Given this list of marker genes TMEM45A, LLGL2, FAM110C, SLFN12, AMPD3, PDE3B, ABHD6, NOD1, SLC2A3, SLC35B4, CEP126, SLC25A33, GREM2, TMEM266, PREX2, BICD1, RUNDC3B, TCF7, FOXRED2, GCH1, TNFSF13B, ITPR1, ADAMTSL3, NIPSNAP1, GLIPR1, C11orf52, GPRC5A, GPR149, INSL6, RAB27B, ZSWIM6, REXO4, GDF15, TMEM109, FRAT1, RBKS, SLC16A13, UCP2, ZNF593, PRRG4, SH3RF3, TMEM141, ALDH7A1 (NCBI Gene Id 64414), IL1RL2, PIK3R5, SH3BP5 (SH3 domain binding protein 5), PCDH9, GREM1, MAN1A1, SPRY4, FETUB, ZNF518B, ATRNL1, CPA6, ACSBG1, BNC1, LPCAT4, SLC4A8, BRINP3, TLE4, CREB5, S1PR3, PLCB1, MRPL35, GATA6, MLF1, MFSD2A, FZD7, LY9, NREP (neuronal regeneration related protein), MRPS31, ARNT2, KIAA1217, OSR1, PHYH, DMRT2, HHAT, CHN2, GATA4, UNC5B, ELOVL4, CTSC, PARM1, KLF4, DNAJC27, DDX19B, EXOC6 (exocyst complex component 6), ZNF595, SRD5A1, DCN, HAVCR2, KIAA1671, WDR31, SYNGR3, STAG3, GPX7, GJB3, TNFSF9, SASH1, AIG1, RNF128, STXBP2, MT1X, WWC1, PTPRG, RBPMS, PEBP1, DNPH1, NAIP, PTPN13, CTSK, HLA-B, WNK3, EZR, DUSP6, FOXQ1, ICA1, EPOR, FBLIM1, DUSP16, MYL9, CRYAB, PRELID3A, KRT19, H2AJ, NEDD9, FEZ1, SCAMP5 (NCBI Gene Id 192683), LPAR2, HIVEP2, NANOS1, OVGP1, RALGAPA2, HECTD2 (HECT domain E3 ubiquitin protein ligase 2), CA12, HS3ST1 (NCBI Gene Id 9957), GPR176, LPAR6, VSTM5, LMO7, PRKAG2, TMEM170B, ARHGAP26, JAM2, ALKBH7, SLC16A3, CMBL, RBM12B, MAP3K6, RCOR2, RAB6B, GDPD1, OLR1, WBP11, SLC35G1, AIM2, SNAI1, ZNF503, LFNG, F2R, TMEM185B, RBM47, DMPK, NOX4, ATOH8, COA3, MPP7, GPR39 (NCBI Gene Id 2863), here is a description of the gene set: Genes up-regulated in the HSC non-supportive stromal cell lines. species: Mus musculus Human Gene Set: DURAND_STROMA_NS_UP Stromal cell lines represent an exceptional tool to study the role on the microenvironment on hematopoietic stem cell (HSC) activity. We have compared the expression profile of HSC supportive vs non-supportive stromal lines generated from different hematopoietic tissues in the mouse, i.e the aorta-gonad-mesonephros (AGM) region, the fetal liver and the adult bone marrow, sequentially activated during development. In this study, six stromal lines were used with one HSC supportive and one non-supportive for each tissue (triplicate samples for each stromal line). We used Mouse Gene 1.0 ST microrrays in combination with GSEA and statistical analysis to identify lists of genes that segregate HSC supportive from non-supportive stromal lines.